Given this list of marker genes ANXA2R, NCAM1, FXYD7, EPHA5, MAST4, KCNQ1, STXBP6, PRSS12, ADRA1A, WNT3A, BTG2, NTNG2, PRDM12 (NCBI Gene Id 59335, PR/SET domain 12), DRD5, LYSMD2, MEOX2, ASTN2, TLE2 (NCBI Gene Id 7089), GRK5, CYP2A7, C2CD4A, NPAS1, DACH2, FBXO3, PIGZ, PDX1, OTOP3, CORO6, NAGS (N-acetylglutamate synthase), SAMD11, IRX1, HOXA1, CRYBA2, STK32B, WNT16 (Wnt family member 16), KCNA3, EGFLAM, ENTPD3, TRIM67, FNDC5, PAPPA, GAB3, OTX2, DCLK2, IRX5, SIX3 (SIX homeobox 3), ECEL1, MECOM, GRM6, CGB7, KCNJ9, FOXE1, SIM2, POLE, MAPT, PRKCH, POLR3GL, TCTE1, FEZ1, OLIG3, SLC26A4, VASH1 (NCBI Gene Id 22846), BRINP2, MNX1, HHAT, MADCAM1, KCNA5, LRCH2, SLCO2A1, LBX1, IRX4, CBX8, CYP39A1 (NCBI Gene Id 51302), ADAMTS15, HS3ST2, EPB41L4A-DT, TMEM88, CR2, OTX1, OTP, HES3, DMRT3, SLC27A2, CCDC140, TNFRSF1B, TSLP, NGFR (nerve growth factor receptor), CACNA1B, SOX9, SHH, UCP1, SLC26A5, SERTM1, CITED1, DLK1, ABTB2, DLL4, FOXG1, PTPRT, ESR1, BMP8A, FOXD4L4, CYP2A6, TMEM132E-DT, GPD1L, TFAP2E, FBXL8, NTN1, RTN4RL2, ZEB2, ZACN, HOXD12, HTR1A, GRK3, ADGRL3, ACADL, ICAM4, FBXL14, ITGA4 (integrin subunit alpha 4), P2RX5, NOL4, MAPK8IP2, SSTR1, ZNF436, CNRIP1, ANKRD20A3P, PARD3B, SLCO3A1, GSC2, TET2, TNFSF9, RGS10, ITIH5 (inter-alpha-trypsin inhibitor heavy chain 5), HNF1B, AATF, ENTPD2 (ectonucleoside triphosphate diphosphohydrolase 2), MED31, BARX1, GPR101 (G protein-coupled receptor 101), IGF2-AS, GALNT18, SOWAHA, NR4A3, LTBP2, REPS2, TBXT, HCN4 (NCBI Gene Id 10021), OLFML2B, PAX6, STMN2, WT1, AMN, EGR4, HAND2, MYOD1, PRKAG2, HOXA6, NBL1, SLFN11, TBR1, GPR26, POU4F2, POU4F1, HES5, RASGEF1C, KCNK2, PKNOX2, SOX7, HOXD8, BNC1, CLEC14A, PAX1, SLITRK3, HS3ST3B1, LINC01101, GRIK3, NXPH4, ARHGEF38, FAM43B, GATA3-AS1, TFAP2D, ADCY4, SIM1, CYP2A13, SLC6A11, SLIT3, AZIN2 (NCBI Gene Id 113451), MYB, HLA-B, AGAP2, MICB, ULBP1, NKX6-2, FLRT2, HLA-F, HOXD13, B4GALNT1, CBX4, SIX2, SEMA4F, NR2F2, HIC1, FGF3, FOXA2, DUOXA2, IL11, TMEM106C, SHOX, ZFHX3, CEMIP, RARA, CHRD, CHST8, SLC30A4, DPY19L2, GPM6B, OLIG2, PTPRN2, NEFH, ILDR2, HTR2C (NCBI Gene Id 3358), ZMYND15, ADARB2, WNT5B (Wnt family member 5B), HSPA1A, KCND3, CAMK2B, ICAM5, PRDM13 (PR/SET domain 13), ATOH1, PABPC1L2A, HOXA13 (NCBI Gene Id 3209), PHOX2A, C14orf132, GDNF, DCHS2, NPAS2, NOTUM, ARHGEF7 (Rho guanine nucleotide exchange factor 7), TLL1, SLC35G1, EIF4E3, PDE10A, GATA4, CHRDL2, TBX5, SLC6A1, EGR2, KAZALD1, GRIA2, ANKRD20A2P, CACNA1G, CLXN, EXOC3L2, DSCAML1, CACNA1D, GNA14, DGKG, CRYBG1, NGF, HOXC11, GRIN2D, HOXD3, TPPP3, PODN, INTS4P1, DYNC1I1, ADAM15, CLSTN2, COL25A1, FOXQ1, TMEM54, ISL1, ZBTB7A, ARL9, IKZF3, VDR, KCNS3, NPTX1, NEUROG1, TRH, PLP1 (proteolipid protein 1), CRLF1, HLX, FOXL2, CSMD3 (NCBI Gene Id 317683), IHH (Indian hedgehog signaling molecule), PADI2, GIMAP5, PCGF5, NCCRP1, COL12A1, COLEC12, C1orf94, NRN1, VSX1, DUSP8, ARL10, EPB41L4A, RAPGEF4, CYP26A1, SECTM1, UCN, NFIX, POU3F1, EVA1C, TBX2, FOXJ1, KCNJ10, PDE8B, SIX6, PAX8, HBA2, EGFL6, PAX7, NTRK1, TLX2, GSC, PIR, LONRF3, SNAI2, ADCY8, SPAG6, CACNG3, SPON2, TMEFF2 (NCBI Gene Id 51753), GPC3, HOXB3, TCEA3, BCL2, NOXO1, CPM, FRMD3, ZIC1, GALR2, ALOXE3, TBXAS1, LRATD1, SHOX2, ZNF436-AS1 (NCBI Gene Id 148898), CSMD2, FZD10, TMEM59L, MCOLN3, SV2B (NCBI Gene Id 9899), NPY5R, GABRG3, NKPD1, WNT7A, NFIA, FOXD2, KLHL13, ANKRD19P, PCDHGC4, KLHL14 (NCBI Gene Id 57565), KL, CALCR, LHX4, NIM1K, HOXA2, ESX1, NFIC, MYO5B, GRIK1, FUT4, NDUFA4L2, CYP26C1, CSF1, OTOP1, RCSD1, TRIM7, RGS20, NELL1, IRF4, POMC, HPSE, COX6B2, MLPH, KCNMA1, ADCYAP1, DUSP15, CAMK2N2, NRXN1, NPAS4, NKX6-1, DGKI, GRHL3, KCNH3, FOXB1, CACNG8, PDE8A, ALX4, ABCC3, DUSP6, COLGALT2, HEYL, DMRT2, CDC20B, GPAT3, PPP1R14C, EN1, UNC5C, SKAP1, CDK5R2, EYA4, NRGN (neurogranin), FGF9, DLX1, AMER2, PPM1E, COMMD3, C17orf100, HPCAL4, RIMS4, BARX2, GPC5, HEY1, HES7, ELAVL2, NKX3-2, SLC40A1, IL1RAPL2, FZD1, ETV7, CALCA, HOXA10, RPS6KA2, ZFYVE28, NKX2-1, SLCO5A1 (solute carrier organic anion transporter family member 5A1), LGI3, GUCY2D, SLC22A3, HOXC5, BHLHE23, PTGDR, RAB9B, RIPPLY2, CHN2, CLCN5, EPHA4, CNNM1, RIPK3, FOXE3, WNT1, KIRREL3, ARHGAP20, KCNK3, GRM7, SPOCK3, FOXC1, LINC02875, CDH23, PAX9, FOXD4L1, LRRC71, GSX2, CACNA1A, PRUNE2, NKX2-3, GNAO1, EFNA1, MLXIPL (NCBI Gene Id 51085), SHC4, SSBP4, ASCL1, KLHL17, NKAIN2, KCNC2, CASZ1, SLC6A20, WT1-AS, DUOXA1, POU3F4, NPR3, DLX4, PCDH8, PAX5, PRRT1, SYT12 (NCBI Gene Id 91683), COL4A5, SLC1A4, NDRG1, LRBA, RTL5, NEUROD2, EPHA3, LAMP5, RNF2, SPTBN4, KLHL35, FAM89A, OTOP2, FAM163A, GABRA2, CNTFR, GABBR2, PHOX2B, CDH4, KCNK13 (NCBI Gene Id 56659), FEZF2, DKK2, BLVRB, RGS9, MEIS1, DPYSL5, KISS1R, SOX17, GRB10, SFRP4, GJB2, CXCL16, DMRT1, ULBP2, PTGER2, B4GALNT2, GPR150, ADAM22, ASCL4, ELMOD1 (ELMO domain containing 1), PTHLH, TAFA4, DNAJC22, LRFN5, GATA3, MIR137HG, CDH7, EPAS1, TIGD3, LGR5, KCNJ3, JUN, GHSR, SPTB, ARL5C, THBD, PTPRU, HAND1, SOX8, TTYH1, GAST, SLC32A1, MAFB, SMOC2, NEFL, HSPA6, PLXNA2, GAD2, PTGER3, ST8SIA4, IL10RA, PDE1B, LPL, RFX6, FAM81A, BHLHE41, TAC1, HOXA9, SLC17A6 (NCBI Gene Id 57084), PCSK2, BMX, HCG9, SMPD3, GDF7, KCNIP4, HHEX, ELAPOR1, CCDC50, RASGRF1, MT1H, PDZD2, OCA2, LHFPL3, CADM4, MSX2, PLEC, NEUROD1, HR, LHX3, HTR7, LMO1, FOXD4L3, FGF11, WSCD1, HOXB1 (homeobox B1), MYF6, CSMD1, NBPF11, POU3F2, HSF4, MMP2, TACR1, MMD2, PRKD1, ONECUT1, LEF1, OSR1 (odd-skipped related transcription factor 1), ANKRD18B, HLA-C, SLITRK1, FGF5, IL7, SFRP5 (secreted frizzled related protein 5), HOXB6, HOXC12, FBLN5, DLX3, RAB11FIP3, LRRTM1, EPHA10, CYP26B1, TGFA, MKX, SLC6A5, SLC17A7, ATP1A3, LHX6, CBLN4, DUOX2, SFTPC, WRAP73, FZD2, CHDH, HSPA1L, LMOD1, TP73, SLC30A10, MT1B, GLIPR2, SATB2-AS1, ZBTB16, PAX2, KCNC4, STC2, NEGR1, NKX3-1, LAMB1, DRD4, CLTRN, NEUROG2, HOXA3, TLX1, ADRB1, C1QTNF5, GRID1, PENK, SEMA6D, LHX5, RPRML, EVX1, FNDC1, RNPEPL1, SLIT1, MT1M, PPP1R13B, SRRM4 (serine/arginine repetitive matrix 4), ANKRD18A, HOXB13, SIX1, PHLDB1, SUSD4, TMEM151A, GRIN1, RGS9BP, PARP8, FRMPD4, PTGR3, ANKRD35, CGB8, DPF3, AVPR1B, SYT6, NPNT, TTLL9, ALOX15, FLI1, COL9A2, TAL1, CYP27B1, HTRA3 (HtrA serine peptidase 3), BCAN, KCNQ5, CLIP4, DACH1, DUOX1, XYLT1, CRH, BATF3, PTGFR, ANKRD20A8P, F2R, SLC6A3, ARID3C, NT5C1A (NCBI Gene Id 92409), HOXC6, MFSD4A (major facilitator superfamily domain containing 4A), ELOVL3, C1QL1, TCAF2, AMPH, WNT2, SNTB1 (syntrophin beta 1), TMOD2, WNT11, ACTL6B, ANKRD20A1, TMEM185A, HPSE2, CCNA1, DNER, SLC25A27, PXMP2, PTH2, AMELX, SLC30A2, MT3, MAN1C1, EBF3, DPY19L2P2, SLC1A2, SCIN, ANKRD27, COL24A1, RIMKLA, NRG2, RNF128, CD70, LHX8, ITPKA, KCNH1, HOXA4, RAB33A, RAB40B, PLXNC1, KCNQ3, PRKCE, HOXB8, CNTN2, ANXA2R-AS1, TMEM30B, CACNA1E, CD47 (CD47 molecule), SLC35D3, SCN4B, DHH, MSC, FRAT1, FUCA1, FBN1, SYNE1, ADRA2A, SHISA6, PTF1A, NEFM, HOXD1, CYP24A1, FUT9, TRIM9, PGR, HOXB7, CDKN2C, SGPP2, GPR62, DIO3, ENSG00000255537, RARRES2, DLK2, LINC01138, ATOH8, RBBP7, SH3GL2, METRNL, CA10, MAL, ZFPM1, FFAR4, NPY1R, SLC9A3, COL27A1, CFAP184, SRD5A2, SYT7, NKX2-8, CRYL1, SIDT1, KCNK4, ALX3, DDAH1, PLPPR1, FBP1, MAPK4, FGF8, CLIC5, ADRB3, GATA2, IGFBP3, HS3ST4, ABCC8, CYP2J2, GCM2, LGALS3, CIDEA, IMPDH1, TTPA, CBR3, DPP6, CHAD, IGSF21, POU4F3, TRPC5, LY6H (NCBI Gene Id 4062), VAX2, CD34, CTNND2, REEP1, MXRA7, DCX (doublecortin), DLX5, UNC5B, AQP5, PRKG1, MLLT3, SATB2, PRLHR, KCNIP2, EPHB1, CBLN1, YAF2, COMP, BARHL2, NKX2-5, PROK2, TMEM255B (transmembrane protein 255B), ERBB4, CDX1, RIMBP3B, IGFBP1, DOK6, GHR, PTGER4, SORCS3, HOXD9, OXCT2, PHYHIPL, PDGFRA, SLIT2, GSN (gelsolin), RAX, RAMP1, NTRK2, C1orf115, TMEM163, SPON1, CD38, ST8SIA5, ELAVL3, GALNT16, GABRB2, PLLP, NRIP3, PAX3, VAX1, EOMES, FOXF1, KLHL1, HOXC8, RAB6C (NCBI Gene Id 84084), SCUBE3, TRADD, RPS6KA6, INA, SORCS1, CRHR1, CD8A, PITX2, PYY, KCNJ4, WNT10A, TTLL7, BMAL1, RFX4, CNNM2, SLC6A2, TBX20, SCTR, GDF6, SCD5, RTBDN, RASL10A, KCNS2, HMX2, TCF21, RSPO2, RTL4, OSBP2 (NCBI Gene Id 23762), GLB1L2, KLF4, TLX3, CHRDL1, DLX2, PITX1, CMTM2, FBLN7, PRKCB, RGCC, COL2A1, KCNJ5-AS1, EGR3, PMP22, ADGRA2, LEKR1, THBS2, FOXL1, MGARP, ASTN1, CRIP1, ST8SIA2, TCEAL1 (transcription elongation factor A like 1), NOC2L, HES2, NIN, TRIM36, DCLK1, NR2E1, NPR1, KCNAB1, FBN2 (fibrillin 2), DUSP4, FIGLA, EN2, KIRREL3-AS3, FEV, PDE4DIP, BHLHE22, GABRA4, INSM2, TWIST1 (NCBI Gene Id 7967), KCNV1, KLK4, KCNA1 (NCBI Gene Id 729214), VSX2, GSX1, ABCG4, EBF1, BRINP3, SOX14, HRK, SHISAL2A, HHIP, PARM1, HOXA7, NIBAN1, NEUROG3, VGLL2, TBX1, ELOVL2, OSR2, HBA1, FRMPD1, DCC, FOXF2, NKX2-2, HOXD4, ADAMTS18, CNTNAP5, HMX3, SLC24A4, RSPO1, FAM78A, MAB21L2, NAV2 (neuron navigator 2), ACP7, LRFN2, HSPA1B, ESAM, SLC10A4, PCDH17, ASCL2, CDH6, ONECUT2 (NCBI Gene Id 9480), HOXC4 (NCBI Gene Id 50712), CDX2, NOVA2 (NCBI Gene Id 4859), SCNN1G, ACAN, GKAP1, SLC9A2, EPHB3, CWH43, KCNH7, APBA1, CH25H, DDX25, PGM5, OAF, ROBO3, RIMBP3C (NCBI Gene Id 150221), ZIC4, CIART, COL8A1, CFAP276, BMP6, SEMA3B, NEURL1, GRIN3A, GBX2, CFAP91, HOXB2, ENSG00000291149, USH1G, VAV3, SSTR2, ANKRD20A5P, HS6ST3, GJD2, LHX2, ZNF503, LMX1B, DTNB (dystrobrevin beta), NRG1, PKP1 (plakophilin 1), INSRR, RIMBP3, CA7, MESP1, DSC3, TRIM28, SLC35F3, HS6ST1P1, COL4A6, RSPO3, CRTAC1, KY, MT1DP, ASIC1, GCC1, CERKL, RASSF5, CHODL, ADAMTS17, ERO1B, FOXD3 (forkhead box D3), GPR88, OVOL1, WNT10B, WNT6, ATF3, INKA1, GUCY1A1, ADAP2, GPR12, CAMK2N1, MAB21L1, FERD3L, SLC30A3, RBP7, FAM167A, IL17RB, HLA-A, PRR18, PSD2, RBP4, LAYN, MSX1, RYR3, CACNB3, ADGRB2, TACSTD2, CXCL14 (NCBI Gene Id 9547, C-X-C motif chemokine ligand 14), KCNK17, ARID5B, BARHL1, STX1A (NCBI Gene Id 6804), MAP6, KCNK12, PRAC1, GPR174, LRP2, TBX21, MT1A, ERICH5, ALKAL1, CRMP1, RUNX2, CHD5, PIP5K1B, IRX3, KIAA1191, FBXO25, HTR6, SNCAIP, DKK1, LTK, SLC16A11, TFAP2B, GATA6, CACNB4, RXRG, SEZ6, ESPN, TBX3, TCEAL8, KCNF1, LRAT, GPR6, TMEM132E, EFNA3, TAP1, OPRD1, IL17D, SFRP1, CLEC4G, FGF20, ISL2, PITX3, here is a description of the gene set: Cancer cells possess traits reminiscent of those ascribed to normal stem cells. It is unclear, however, whether these phenotypic similarities reflect the activity of common molecular pathways. Here, we analyze the enrichment patterns of gene sets associated with embryonic stem (ES) cell identity in the expression profiles of various human tumor types. We find that histologically poorly differentiated tumors show preferential overexpression of genes normally enriched in ES cells, combined with preferential repression of Polycomb-regulated genes. Moreover, activation targets of Nanog, Oct4, Sox2 and c-Myc are more frequently overexpressed in poorly differentiated tumors than in well-differentiated tumors. In breast cancers, this ES-like signature is associated with high-grade estrogen receptor (ER)-negative tumors, often of the basal-like subtype, and with poor clinical outcome. The ES signature is also present in poorly differentiated glioblastomas and bladder carcinomas. We identify a subset of ES cell-associated transcription regulators that are highly expressed in poorly differentiated tumors. Our results reveal a previously unknown link between genes associated with ES cell identity and the histopathological traits of tumors and support the possibility that these genes contribute to stem cell-like phenotypes shown by many tumors. Human Gene Set: BENPORATH_ES_WITH_H3K27ME3 from publication Ben-Porath I, Thomson MW, Carey VJ, Ge R, Bell GW, Regev A, Weinberg RA (PMID 18443585) Set 'H3K27 bound': genes posessing the trimethylated H3K27 (H3K27me3) mark in their promoters in human embryonic stem cells, as identified by ChIP on chip. studied in species Homo sapiens